Given this list of marker genes Nefh, Hip1, Ttc39b, Ubqlnl, Pld5, Ar, Tent4a (NCBI Gene Id 210106), Mmp14, Ap3s2, Prps1l3, Klrd1, D830030K20Rik, Hecw1, Nxph3, Larp1, Aff1 (AF4/FMR2 family, member 1), Clic5, Fgf13 (NCBI Gene Id 14168), Klf12, Mecp2, Tfcp2l1, Lce6a, Pkm, Gstm2, Psd, Elovl4, Det1, Nhsl3, Nrxn2, Nfat5, Chtf8, Pex26, Snap25, Bpifa3, Fcho2, Fign, D16Ertd472e, Prrc2b, AU018091, Baiap2, Hipk3, Pcdhb13 (NCBI Gene Id 93884), Gss, Adarb2, Cpsf2, Gigyf1, Slc8a1, Pierce1, Gpr12, Dock5, Sumo1, Gm826, Trank1, Usp17la, Wdr46, Zfp268, Ppp2r2a, Mlph, Gripap1, Celf4, Hsd3b4, Slc26a2, Cd300lg, Usp50, Mapre3, Rps6ka6, Fam81a, Nlgn1, Cfap70, Tox, Atp1b2, Fem1b, Ap2m1, Thrb, Osbp2, Atf7, Gm11437, Itga4, Tnrc6b, Gnas, Ccdc71, Zfp609 (zinc finger protein 609), Pappa, Ube2q2, Xpr1, Tasor, Mdm4, Glcci1, Dmgdh, Cbl, Appbp2, Cpsf7, Snx15, Pde5a, Lrig2, Ighmbp2, Arcn1, Cant1, Man1c1, Rcc2, Prps1, Pappa2, Kdm3b, Lif, Ago3, Edem2, Mettl26, Riok1, Strada, Iqgap3, Grk4, Csn2, Zc3h7b, Krtap13-21, Dgkk, Slc6a8, Trim30b, Polr1h, Hsd3b8, Dcaf7, Nup155, Elp3, Arhgef9, Cbx2, Hyou1, Esrrg, Iws1, Mlf2, Parp9, A1cf, Ptbp3, Slc22a16, Rgs8, Psd3, Dedd, Zfp292, Mga, Pik3cb, Strbp, Hoxb9, Gprc5b, Nck2, Sprr2a1, Aak1, Tlr4, Pea15a (proliferation and apoptosis adaptor protein 15A), Ccnh, Phex, Lzts3, Sh3pxd2a, Wipf2, Zfp984, Cap1 (NCBI Gene Id 12331), Nectin1, Ago1, Gnpda2, Plcd4, Vps25, Med13, Gls, Rnf217, Stim2, Creb5, Mgat4c, Kdm2b (NCBI Gene Id 30841), Gtf2e1, Ctf2, Map4k2, Tbc1d25, Ccn3, Hrk, Prss3b, Fbln5, Kcnd1, Srgap1, Dusp10, Pam, Mpz, Sox14, Lratd1, Orai2, Dock3, Chd3, Maff, Kmt2a, Rictor, Zfp936, Arf3, Trim66, Khsrp, AB124611 (NCBI Gene Id 382062), Phf2, Rdx, Cacna1e (NCBI Gene Id 269133), Sprr2a2, Sec63, Npas4, Col5a3, Noct, Creb3l2, Pla2g4c, Prok2, Atp11c, Tapt1, Brca2, Gm10408, here is a description of the gene set: Mouse Gene Set: MIR_7010_5P Genes predicted to be targets of miRBase v22 microRNA mmu_miR_7010_5p in miRDB v6.0 with MirTarget v4 prediction scores > 80 (high confidence targets). from publication Chen Y, Wang X (PMID 31504780) studied in species Mus musculus